Given this list of marker genes Diaph1, Hrh1, Gabrb2, Gabrg2, Gabrb3, Gabra1, Gabrb1, here is a description of the gene set: Any process that results in a change in state or activity of a cell (in terms of movement, secretion, enzyme production, gene expression, etc.) as a result of a histamine stimulus. Histamine, the biogenic amine 2-(1H-imidazol-4-yl)ethanamine, is involved in local immune responses as well as regulating physiological function in the gut and acting as a neurotransmitter. studied in species Mus musculus Mouse Gene Set: GOBP_CELLULAR_RESPONSE_TO_HISTAMINE